The following is a description of a gene set: Human Gene Set: GOBP_T_CELL_RECEPTOR_SIGNALING_PATHWAY The series of molecular signals initiated by the cross-linking of an antigen receptor on a T cell. studied in species Homo sapiens, and this is the list of marker genes: DENND1B, CEACAM1, UBASH3A, RC3H2, PTPRJ, CD2AP, LIME1, HLA-DPB1, HLA-DRB1, THEMIS, HLA-DRB3, CACNB4, GATA3, LGALS3, CTLA4, PLCG1, BTK, MAPK1, MAP3K7, ZC3H12A, SH2D1A, HLA-DQB1, RPS3, NECTIN2, PHPT1, FYN, IKBKB, UBE2N, TRAF6 (NCBI Gene Id 7189), PIK3CA, PDE4D (phosphodiesterase 4D), FOXP3, PVRIG, CD8A, VTCN1, BTRC, NFKBID, ABL1, CD28, CBLB (Cbl proto-oncogene B), TRAC, LCP2, HLA-A, EIF2B4, CRKL, MOG, LAT, RELA, WNK1, CCR7, SHB, BTNL2, BTN2A1, RFTN1, ZNF683, RC3H1, RIPK2, PIK3CD, CD8B, FYB1, TRGC1, LIPA, LCK, RAB29, DUSP3, HHLA2, UBR2, BCAR1, CD300A, GBP1, BTNL10P, FCHO1, ITK, CD247, PTPN6, PTPN22, EIF2B5, EIF2B3, TESPA1, MALT1, HRAS, TNFRSF21, TXK, CYLD, PRKD2, LAPTM5, BTN1A1, CARD11, ZAP70, PSEN1, SLA2, FYB2, ADA, RBCK1, BCL10, PRAM1, PDE4B, BTN2A3P, TRAT1, TRDC, PLCG2, CSK, ITPRIPL1, IKBKG, FOSL2, DGKZ, NCK1, TRBC1, RNF31 (ring finger protein 31), BTN2A2, CD3G (CD3 gamma subunit of T-cell receptor complex, NCBI Gene Id 917), EIF2B2, EIF2B1, THEMIS2, CD160, BTNL3, PRNP, DUSP22, THY1, BRAF, PTPRC, TRBC2, LILRB4, PTPN2, CACNB3 (calcium voltage-gated channel auxiliary subunit beta 3), TRGC2, ELF1, CD3D, PAWR, BTN3A3, CD3E, INPP5D, CD81, TEC, ERMAP, STOML2, BTN3A1, KHDRBS1, BTNL9, STK11, SKAP1, CD226, SIVA1, BTN3A2, EZR, SPPL3, ICOSLG, NFKBIZ, SLC39A6, BTNL8, CD276, KCNN4